Given this list of marker genes Tmod1, Bfsp2, Nf2, Tgfb1, Ntrk3, Smad3, Vim, Spred2, Slc7a11 (solute carrier family 7 (cationic amino acid transporter, y+ system), member 11), Plaat3, Epha2, Skil, Zeb2, Atf4, Cryaa, Kdm5b (lysine demethylase 5B), Crygd, Pitx3, Crygb, Fgfr3, Frs2, Tbc1d20, Maf, Fgfr2, Cdkn1c, Hsf4, Prox1, Fgf2, Plaat1, Spry1, Abi2, Bfsp1, Fzr1, Spred1, Tdrd7, Smarca4, Spry2, Six3, Spred3, Foxe3, Cdkn1b, here is a description of the gene set: Mouse Gene Set: GOBP_LENS_FIBER_CELL_DIFFERENTIATION The process in which a relatively unspecialized cell acquires specialized features of a lens fiber cell, any of the elongated, tightly packed cells that make up the bulk of the mature lens in the camera-type eye. The cytoplasm of a lens fiber cell is devoid of most intracellular organelles including the cell nucleus, and contains primarily crystallins, a group of water-soluble proteins expressed in vary large quantities. studied in species Mus musculus